The following is a description of a gene set: Craniofacial disproportion Human Gene Set: HP_CRANIOFACIAL_DISPROPORTION studied in species Homo sapiens, and this is the list of marker genes: IGF2, FIG4, CA2, LMNA, KCNA1, ZMPSTE24